The following is a description of a gene set: Congenital fibrosis of extraocular muscles Congenital non-progressive ophthalmoplegia with multiple extraocular muscle restrictions. Typically, there is ptosis and variable degrees of restriction of horizontal and vertical eye movements. Human Gene Set: HP_CONGENITAL_FIBROSIS_OF_EXTRAOCULAR_MUSCLES species: Homo sapiens, and this is the list of marker genes: PHOX2A, COL25A1, TUBB3, TUBB2B, KIF21A, TUBA1A